Given this list of marker genes TREM2, CSF1R, DOK1, MST1R, STAP1, CSF1, PTPN2, here is a description of the gene set: species: Homo sapiens The series of molecular signals initiated by the binding of the cytokine macrophage colony-stimulating factor (M-CSF) to its receptor on the surface of a target cell, and ending with the regulation of a downstream cellular process, e.g. transcription. Human Gene Set: GOBP_MACROPHAGE_COLONY_STIMULATING_FACTOR_SIGNALING_PATHWAY